The following is a description of a gene set: Genes predicted to be targets of miRBase v22 microRNA hsa-miR-4802-5p in miRDB v6.0 with MirTarget v4 prediction scores > 80 (high confidence targets). from publication Chen Y, Wang X (PMID 31504780) studied in species Homo sapiens Human Gene Set: MIR4802_5P, and this is the list of marker genes: TFAP2D, ATAT1 (NCBI Gene Id 79969), ZFP91, CBLB, RBMY1D, OR2H1, RBMY1A1, CCNL1, LMLN, LMO7DN, C16orf46, EDIL3, AGBL1, TTI2, HMGN4, CAPN6, RSL1D1, GALP, RBMY1E (RNA binding motif protein Y-linked family 1 member E), ATP1B1, FAM169BP, CCNA1, BAX, GDPD4, STOX2, EIF5, WNT16, HOMER1, FILIP1L, CCL4, SMS, YTHDC1, ATAD2B, WASF1, DLX6, ESRRG, SCAMP1, KDM2A, CUL2, MDGA2, SH3RF1, MPDU1 (NCBI Gene Id 9526), ABHD13, DCLK1, TRIM41, CALM2 (NCBI Gene Id 805), PEG10, PRUNE2, DNAJA2, PEAK1, LAMA1, NMT2, CTNNA3, HECW1, MAT2B, SPAG1, VWC2, RBMY1F (RNA binding motif protein Y-linked family 1 member F), ITGA4, HGF, FUBP3, ORMDL2, SPAG17, CAPZB